Given this list of marker genes CHAT, ACHE, PCYT1A, LPIN1, CEPT1, SLC44A2, SLC44A1, SLC44A3, SLC44A5, STARD7, ABHD3, PCYT1B, CHKA, CSNK2B, MFSD2A, LPIN2, CHPT1, CSNK2A1 (casein kinase 2 alpha 1), LPIN3, CHKB, PHOSPHO1, BCHE, CSNK2A2, PCTP, SLC44A4, STARD10, PEMT, LPCAT1, here is a description of the gene set: Human Gene Set: REACTOME_SYNTHESIS_OF_PC Synthesis of PC species: Homo sapiens